Given this list of marker genes CRMP1, DPYSL3, TDG, APOBEC3C, NT5C, OGG1, STPG4, CDADC1, DPYD, ALDH6A1, NEIL2, AICDA, UPP2, DCTPP1, UNG, DPYSL5, UPP1, NEIL1, DPYS, ENTPD4, SMUG1, ENTPD7, DCTD, NT5M, ENTPD5, DPYSL2, DUT, CDA, UPB1, APOBEC3G, DPYSL4, MBD4, TYMP, NTHL1, here is a description of the gene set: Human Gene Set: GOBP_PYRIMIDINE_CONTAINING_COMPOUND_CATABOLIC_PROCESS species: Homo sapiens The chemical reactions and pathways resulting in the breakdown of a pyrimidine-containing compound, i.e. any compound that contains pyrimidine or a formal derivative thereof.